Given this list of marker genes EGF, HES1, NCSTN, PLXND1, KAT2A, YBX1, NOTCH3, HEY1, HEYL, UBA52, KAT2B, STAT1, MIB1, CREBBP, DLL1, MAML1, TACC3, FABP7, IKZF1, NEURL1B, DLGAP5, PSENEN, EGFR, EP300, MAMLD1, WWC1, RPS27A, NEURL1, WWP2, JAG2, MIB2, RBPJ, SNW1, MAML2 (mastermind like transcriptional coactivator 2), PSEN1, HEY2, UBC, APH1A, PSEN2, APH1B, DLL4, PBX1, PTCRA, UBB, ADAM10, HES5, NOTCH1, JAG1, MAML3, here is a description of the gene set: Similar to NOTCH1, NOTCH3 is activated by delta-like and jagged ligands (DLL/JAG) expressed in trans on a neighboring cell. The activation triggers cleavage of NOTCH3, first by ADAM10 at the S2 cleavage site, then by gamma-secretase at the S3 cleavage site, resulting in the release of the intracellular domain of NOTCH3, NICD3, into the cytosol. NICD3 subsequently traffics to the nucleus where it acts as a transcriptional regulator. NOTCH3 expression pattern is more restricted than the expression patterns of NOTCH1 and NOTCH2, with predominant expression of NOTCH3 in vascular smooth muscle cells, lymphocytes and the nervous system. Based on the study of Notch3 knockout mice, Notch3 is not essential for embryonic development or fertility.<p><p>Germline gain-of-function NOTCH3 mutations are an underlying cause of the CADASIL syndrome - cerebral autosomal dominant arteriopathy with subcortical infarcts and leukoencephalopathy. CADASIL is characterized by degeneration and loss of vascular smooth muscle cells from the arterial wall, predisposing affected individuals to an early onset stroke. NOTCH3 promotes survival of vascular smooth muscle cells at least in part by induction of CFLAR (c FLIP), an inhibitor of FASLG activated death receptor signaling. The mechanism of NOTCH3 mediated upregulation of CFLAR is unknown; it is independent of the NOTCH3 coactivator complex and involves an unelucidated crosstalk with the RAS/RAF/MAPK pathway.<p><p>In rat brain, NOTCH3 and NOTCH1 are expressed at sites of adult neurogenesis, such as the dentate gyrus. NOTCH3, similar to NOTCH1, promotes differentiation of the rat adult hippocampus derived multipotent neuronal progenitors into astroglia. NOTCH1, NOTCH2, NOTCH3, and their ligand DLL1 are expressed in neuroepithelial precursor cells in the neural tube of mouse embryos. Together, they signal to inhibit neuronal differentiation of neuroepithelial precursors. Expression of NOTCH3 in mouse neuroepithelial precursors is stimulated by growth factors BMP2, FGF2, Xenopus TGF beta5 - homologous to TGFB1, LIF, and NTF3.<p>In mouse telencephalon, NOTCH3, similar to NOTCH1, promotes radial glia and neuronal progenitor phenotype. This can, at least in part be attributed to NOTCH mediated activation of RBPJ-dependent and HES5-dependent transcription.<p>In mouse spinal cord, Notch3 is involved in neuronal differentiation and maturation. Notch3 knockout mice have a decreased number of mature inhibitory interneurons in the spinal cord, which may be involved in chronic pain conditions.<p><p>NOTCH3 amplification was reported in breast cancer, where NOTCH3 promotes proliferation and survival of ERBB2 negative breast cancer cells, and it has also been reported in ovarian cancer. NOTCH3 signaling is involved in TGF beta (TGFB1) signaling-induced eptihelial to mesenchimal transition (EMT)<p><p>NOTCH3 indirectly promotes development of regulatory T cells (Tregs). NOTCH3 signaling activates pre-TCR-dependent and PKC-theta (PRKCQ)-dependent NF-kappaB (NFKB) activation, resulting in induction of FOXP3 expression. Deregulated NOTCH3 and pre-TCR signaling contributes to development of leukemia and lymphoma. Reactome Pathway: Signaling by NOTCH3 studied in species Homo sapiens part of: Signaling by NOTCH